The following is a description of a gene set: Genes predicted to be targets of miRBase v22 microRNA mmu_miR_669o_5p in miRDB v6.0 with MirTarget v4 prediction scores > 80 (high confidence targets). Mouse Gene Set: MIR_669O_5P from publication Chen Y, Wang X (PMID 31504780) species: Mus musculus, and this is the list of marker genes: Bag4, Ppp1r3a, Tmem260, Vps35, Asf1a, Ankib1, Zeb2, Agfg1, Fam13c, Kcnq3, Ttpa, Surf2, Fermt2, Sgk1, Chil5, Lce1m, Ubr7, Pde5a, Slc25a27, Fras1, Pcnp, Dusp4, Gm11780, Ap3m1, Wtap, Ivl, Golgb1, Ddi2, Mbnl3, Kpna1, Plpp3, Arfgef3, Dmd, Naaladl2, Zbtb41, Slc17a6, Gstt1, Vsx1, Glce, Cnst, Vip, Morc3, Bambi, Ano5, Aar2